The following is a description of a gene set: studied in species Mus musculus Fatty acyl-CoA biosynthesis Mouse Gene Set: REACTOME_FATTY_ACYL_COA_BIOSYNTHESIS, and this is the list of marker genes: Elovl5, Hacd2, Cbr4, Tecr, Hacd4, Ppt2, Scd2, Acsbg2, Morc2a, Acsl6, Acsl3, Elovl6, Slc27a2, Elovl3 (NCBI Gene Id 12686), Hsd17b8, Acsf3, Elovl7, Elovl2, Acaca, Acsl4, Hsd17b12, Fasn, Acsl1, Hsd17b3, Acly, Elovl1, Acsbg1, Hacd3, Acsl5, Ppt1, Hacd1, Tecrl